The following is a description of a gene set: from publication Lang G, White JR, Argent-Katwala MJ, Allinson CG, Weston K (PMID 15608679) Mouse Gene Set: LANG_MYB_FAMILY_TARGETS Myb family target genes. Hematopoiesis, the process by which mature blood cells arise, is controlled by multiple transcription factors, which act in stage- and lineage-specific complexes. It is a major goal to elucidate the genes regulated by these transcription factors, in order to obtain a full understanding of the process and its malignant counterpart, leukemia. Myb family transcription factors play a central role in hematopoiesis. To identify new Myb family target genes, we have used an inducible dominant-negative protein for a subtraction cloning protocol in a model cell system (FDCP-Mix) with many characteristics of normal hematopoiesis. We present here a novel group of 29 validated Myb family target genes of diverse functions. studied in species Mus musculus, and this is the list of marker genes: Actn1, Ppp3ca, Iqgap1, Tfec, Bet1l, Slc20a1, Set, Cd53, Copa, Slc1a5, Msn, Cct2, Api5, Birc2, Timm44, Sec31a, Emilin2, Tfb1m, Clta, Hspa8, Mad1l1, Hspa13, Zdhhc21, Slc25a3, Nsun2, Psd4, Fam107b, Casp6, Cbx4